The following is a description of a gene set: studied in species Homo sapiens Any cellular process that depends upon or alters the microtubule cytoskeleton, that part of the cytoskeleton comprising microtubules and their associated proteins. Human Gene Set: GOBP_MICROTUBULE_BASED_PROCESS, and this is the list of marker genes: IQCG, DNAI4, TUBB2A, SLC22A16, SKA1, CAPN6, CATSPER3, TAC3, KIF13B, KIFAP3, CWH43, CDK5, AP3M1, STMN3, NLRP5, NME7, CFAP45 (cilia and flagella associated protein 45), FOXJ1, TUBG1, CLXN, RNF19A, CFAP90, GARIN2, ARHGAP21, SUGT1, ENKD1, TUBA1A, NEURL1 (NCBI Gene Id 9148), ODF2, KXD1, SPIRE2, IRGC, DYNLRB1, SPAG16, VPS4B, KIZ, DYNC1I1, DRG1, NUMA1, BBS2, TCTE1, RTTN, TTLL7, CYLD, CETN3, HSPB1, CENPJ, MLH1, SEMG1, CHMP4B, MAPRE1, IFT122, PARD3, NUDC, CYB5D1, CCDC102B, C2CD6, CPLANE2, FIGNL2, CCDC88A, GJA1, CFAP70, CALML4, PCNT, TUBB1, SMCP, KATNIP, BCCIP, NUF2, RSPH6A, DNALI1, VCP, DNAI2, CDK5R1, CEP350, STAG2, LSM14A, ACTR2, ABL1, CCDC78, KIF2B, KIF21B, TRAK2, ARL2, TMEM108, MAP1A, TRAF3IP1, HTT, CFAP46, CATSPER2, DNAL1, EPPIN, DNHD1 (dynein heavy chain domain 1), KLC4, IFT22, DRC7 (dynein regulatory complex subunit 7), TEKT2, CFAP58, CENPA, SPAG8, IFT52 (intraflagellar transport 52), DNAAF8, CEP20, CFAP206, CAMSAP1, PAX6, CCDC103, RHOT2, TRPV4, LZTS2, TNP1, KIF28P (NCBI Gene Id 100130097), DNAH2, PTPA, TOGARAM1, CCNB2, NEDD1, MECP2, CCDC61, CEP152, RP1L1, AKAP4, DNAH12, PARD6B, RAC1, ARMC2, SIK3, PKHD1, GOLGA2, BMERB1, SASS6, CCDC13, CLASP1, TUBB4B, APC, GIT1, KLC2, YIF1B, TTK, CCSAP, EPHA3, CCDC68, SPIRE1, PLK4, LRRC23, IFT20, CHMP7, IFT70A, DNAH14, TUBE1, KIF6, MEMO1, UHRF1, CCDC39, TMEM67, DNAAF6, DVL1, IFT172, ADCY3, EFHC1, FSD1, MCPH1, RCC1, DCLK2, RAB27B, E2F4, ATXN7, CDK11B, SKA3, PPFIBP1, BLOC1S5, AP3M2, WDR62, TLE6, GTSE1 (NCBI Gene Id 51512), TBCEL, IFT25, RAB6A, KASH5, CCDC38, CHMP1A, KIF16B, CFAP141, TPGS1, PEX14, APOB, TLN1, MAP1B, HAUS8, KIF13A, PURA, SLC39A12, IFT140, TUBGCP2, INO80, CLUAP1, KAT2A, CC2D2A, KIF5B (NCBI Gene Id 3830), PDCL2, SPAG1, PRC1, TTLL4, CFAP210, CHD3, CCNB1, CFAP161, TTLL8, SMC3, CCDC15, KIAA0753, CFL1, OCLN, CCDC40, FBXW5, DUSP21, PHLDB1, KNSTRN, KPNB1, CDCA8, NINL, C10orf90, KANK1, BLOC1S6, TEKTL1, PRM3, PFN4, RUFY4, CCDC66, KATNB1, USP33, CEP70, KIF26A, BIRC5, MAP7D3, DYNLRB2, MYBL2, ASPM, ZMYND10, BNIP2, CATSPERE, KIAA1614, DNAAF5, ATXN3, SPATA7, DYNLT4, SPA17, VANGL1, TTLL13, AKAP3, ZMYND12, TUBGCP3, CFAP65, INTS13, NEFH, DYNC2H1, BORCS8, DLG2, IQCA1L, CFAP276, SRGAP2C, CDH5, DYRK1A, SIRT1, KLHL42, NME5, ODAD2, ARHGEF7, MAP3K11 (NCBI Gene Id 4296), MAP7D2, TUBD1, KIF9, HOOK1, NIN (ninein, NCBI Gene Id 57681), NDEL1, CROCC, HAUS5, HDAC6, PIERCE2, SLIRP, PLK1, SRGAP2, UCHL1, TACC2, DNAAF11, PPP2R1B, SOD1, LCA5, IFT56, ATG5, AFG2B, HSPA1A, HSPA1B, KIF22, PARD3B, CEP97, FBXO5, POC1B, ARMC12, GAS2L1, PACRG, RNASE10, DNAAF3, KIF2A, PCM1, PKD1, ATP1A4, CKAP5, SPAG6, PTEN, WASHC5, BCL2L10, MAPK8IP3, RABL2B, ITGB1BP2, MNS1, CDKN1B, DYNLT3, CEP120, CDC20, CHORDC1, TMEM201, BRSK1, SENP6, TTLL5, CILK1, OFD1, CCDC8, FGF13, PARP3, AURKA, KIF12, ARL8A, EFHC2, POC5, TMEM230, PDCD6IP, TUB, TEKT5, DNAH5, RAN, KLC1, CFAP91, SON, KTN1, CIMIP2A, BORCS6, DNAAF1, SEPTIN4, DNAH1, NUSAP1, TPPP, CHEK1, CALML6, CSAG1, SDCCAG8, CUL9, APC2, CATSPERZ, GAS8, EML2, ERBB2, FIGN (NCBI Gene Id 80249), COPG1, SAPCD2, ILK, RAB1A, SLAIN1, CHMP3, HNRNPU, RIPOR2, CNTROB, BLOC1S2, INTU (inturned planar cell polarity protein), CRYAB, KIFBP, KIF3B, TBCD, KIFC2, RASGRP1, BORA, RFX3, EZR, CDC20B, CHMP2B, GMNC, HOOK2, SMC1A, ODAD3, FLOT2, ESPL1, TUBG2, GADD45A, ROPN1, MET, CEP128, CHMP5, GBA2, CLASP2, NEK6, AP3D1, EFCAB9, IFT27, KIF14, CCNF, CDK11A, UBXN2B, CCDC65, LZTFL1, ATF5, GAS2L2, UVRAG, NSFL1C, GK2, NPHP3, FBXO24, DNAAF2 (NCBI Gene Id 55172), SPEM3, HAUS4, DNAI1, DYNC2LI1, SKA2, CKAP2, SLC22A14, CEP43, ACTR10, GEN1, PGK2, RANBP1, STK11, SEPTIN1, FEZ1, CAV3, CFAP57, TBC1D21, SUN2, RPS3, PLK2, DST, KIF4B, SPMIP11, PRDM14, MAP7, MARK1, MAPK15 (NCBI Gene Id 225689), NAT10, ARL8B, TUBAL3, CFAP69, CLIP4, TRIM36, KIF2C, TTC21A, BBS12, DYNLT1, GABARAP, DNAH7, SPEF1, IQUB, PEX13, NAV3, RHO, CIMAP1A, RHOT1, LLGL1, CNTN2, RSPH1 (radial spoke head component 1), LRRC61, WDR35, SUN1, EML3, HSBP1, TEKT4, MCIDAS, CCNL2, RSPH9, RAB11A, DNM2, CABS1, KATNBL1, CCDC120, CHMP4C, HAUS2, STMN4, TUBA1C, ZW10 (NCBI Gene Id 9183), ALMS1, CFAP73, CFAP52, OOEP, MAP7D1, FUZ, INPP5B, CEP85, SPRY2, POC1A, MGARP, NEFL, RANGRF, HEPACAM2, DNAH9, PARD6G, BICD1, IFT70B, PSRC1, CDC14B, SYNE2, IQCA1, CHEK2, INCENP, AGBL4, TERF2, TUBB3, FKBP4, CDK1, ADAM7, DCTN1, NEK10 (NIMA related kinase 10), CEP76, CEP295, MOS, TEX101, HIF1A, PRSS55, KIF5A, HAUS1, RAB21, SPAST, LDHC, WDR90, RANBP9, SPMIP9, COPG2, TRAK1, CSNK1D, RAB17, PHLDB2, ATRX, ADCY10, KIF1C, SFPQ, PRKAA1, CEP19, AXIN1, UXT, SPG11, KATNAL1, MID1IP1, DYNC1LI2, SLK, UBE2B, PLK5 (polo like kinase 5 (inactive)), ZNF207, HAUS3, CDR2L, BLOC1S3, TTLL9, KIF21A, GNAI1, TRDN, IQCF1, CFAP119, C2CD3, CHP1, CNTLN, CELSR2, PRICKLE1, CAMSAP3, ACTR3, MARK4, MTCL1, TUBA3E, CLTC, HAP1, PEX1, NPHP4, MAPRE3, STAU2, CFAP107, MAPT, TUBB, DNAAF4, WDR19, CCNL1, RABGEF1, ING2, IFT74, CEP192, DLG1, DNAI3, CIMIP2C, EFNA5, KATNA1, CHMP6, TOGARAM2, SSX2IP, CATSPER4, DYNLL2, TACR1, NUP62, CFAP54, ANKRD53, GCC2, TACR2, XPO1, PLA2G3, LMNA, STAG1, FES, SPICE1, RIBC2, STARD7, CFAP43, NME8, IFT43, AQP4, KIF18A, DPCD, DNAH8, VDAC3, NCKAP5L, IFT81, MAP10, KIFC3, TRIM46, TTLL3, KIAA0319L, DIAPH1, MAP2, CDK2AP2, BLOC1S1, CCDC187, LRRC46, LRGUK, TSSK6, DYNC2I2, DRC1, DCTN2, NDE1, TTL, TUBA3C, GAS2L3, ANKFN1, CEP44, IFT57, CENATAC, TEKT3, TUBA4A, VPS13A, PLK3, CLIP3, TUBGCP4, CUL7, SLC9B2, NEK7, BAG3 (NCBI Gene Id 9531), RHOA, DZIP1, BRSK2, STMN2, DEFB1, PKD2, CAMSAP2, GAPDHS, SPC25, SPMIP8, HOATZ, SPDL1, DCAF13, MEIG1 (meiosis/spermiogenesis associated 1), KIF3A, PRUNE1, TXNDC9, BBS1, KIF7, GSK3B (NCBI Gene Id 2932), STMND1, DDB1, CFAP53, SPEM1, TUBB4A, ULK4, TNKS, JHY, TPX2, GSK3A, TBCB, AP3B2, CFAP221, KIF11, MAFIP, MARK3 (NCBI Gene Id 4140), CENPE, KIF19, CLN3, LLGL2, CCDC159, CETN1, KATNAL2 (NCBI Gene Id 83473), KIF27, DNAAF10, TACC3 (transforming acidic coiled-coil containing protein 3), LIMK2, TTC29, CEP126, STARD9, MAK, CCDC146, DNAJB13 (NCBI Gene Id 374407), MDM1, PPP2R1A, ZBED3, RAE1, GARIN3, QRICH2, PPFIA1, ARHGEF2, TRIM58, LCA5L, NDC80, NPM1, CCP110, HOOK3, CCSER2, TSSK4, BICDL1, KIF15, VBP1, SGO1, SPECC1L, RSPH4A, RACGAP1, EFCAB11, CGN, CCNYL1, TMF1, DAW1, ARMCX3, KIF1A, FNTB, PIBF1, BICDL2, STAU1, KLC3, ROPN1B, SEMG2, DYNC1I2, UBB, NAV1, TPR, WDR47, DYNC2I1, CFAP20, TTC12, DNAL4, FGF10, CCDC88C, RBM14, DNAH10, APP, KIF20B, DIXDC1, XRCC3, MAP4, HAUS7, NTMT1, RP1, MKKS, CCR6, CDC14C, LAMP1, GAPDH, TUBA1B, HDAC3, CFAP100, ARL3, CEP63, EFHB, FBXW11, TTLL1, CRYAA, MAP2K1, NCOR1, PPP1R12A, DYNLL1, DCTN3, PGAM4, NETO1, CEP72, CHMP1B, XRCC2, TAOK1, WNT3A, AP3S2 (adaptor related protein complex 3 subunit sigma 2), DYNC1LI1, ASH1L, TUBB8B, WEE1, ROCK1 (NCBI Gene Id 6093), KIF23, ROCK2, AKAP9, WASF1, TTLL11, ROPN1L, SPMIP6, TTLL2, OBSL1, CFAP97D1, TTC21B, NHERF1, PRKAA2, FAM110A, IFT80, DOCK7, AURKB, SETD2, NUBP1, ABRAXAS2, TUBB6, STMN1, MAP6, SPACA9, GTF2B, CFAP157, DEUP1, TAC1, SSNA1, CFAP61, MISP, TAC4, KAT2B, DYNLT5, CENPH, BCAS2, TUBA3D, RUFY3, CEP295NL, CDC14A, PPP1R35, CALML5, ITGB1, FYCO1, CFAP77, WRAP73, CCDC63, LRPPRC, CIB1, BORCS7, RMDN1, CFAP126, TMEM232, EML4, KIFC1, TACC1, SBDS, SYBU, DNAH6, OPA1, CFAP144, TEKT1, SLC16A1, KAT5, ODAD1, ATAT1 (NCBI Gene Id 79969), AUNIP, CFAP95, SLAIN2, BRCA1, KIF18B, SPAG17, TRIM54, MAP1S, DNAH3, KIF25, FSIP2, MREG, SORD, KIF3C, FLNA, MAP9, TRIM37, CATSPERD, FER, CCDC170, PLTP, TACR3, SPAG5, DCX, ATP2B4, ABRAXAS1, STIL, DIAPH3, TUBB8, RPGR, AURKC, KIF5C, PAFAH1B1, IGBP1, RNF4, DISC1, CCDC42, BBS4, KIF17, CFAP298, CFAP68, AP3B1, SPMIP10, APBA1, GPSM1, CFAP251, DNAH17, SAC3D1, PCLAF, MACF1 (microtubule actin crosslinking factor 1), CFAP44, MYH9, CHMP4BP1, PIERCE1 (piercer of microtubule wall 1), TBCE, ENKUR, ZPR1, CDK2, POLDIP2, KIF4A, WDR73, ARHGEF10, IFT46, RANBP10, FAM107A, CHMP2A, CEP68, SS18, TTBK2, CCDC69, IFT88, ODAD4, MAD2L1, MID1, HAUS6, EML1, CLIP1, CEP135, TUBB2B, CCDC57, HYDIN, BBOF1, AGTPBP1, PRKCZ, PIN1, TPPP3, ATG16L1, DCTN6, INPP5J, RGS14, CEP250, PPP2CA, MAPRE2, KIF26B (NCBI Gene Id 55083), DLGAP5, CETN2, RAB6C, CABYR, SPRY1 (sprouty RTK signaling antagonist 1), TUBGCP5, PARD6A, KIF20A, SLC9B1, CHMP4A, CELF3 (CUGBP Elav-like family member 3), ARMC3, SAXO4, CFAP74 (cilia and flagella associated protein 74), TUBA4B (tubulin alpha 4b), TEKTIP1, TUBGCP6, DAG1, BRCA2, TPPP2, TUBA8, BLOC1S4, BORCS5, PPP2CB, CTNNB1, EFCAB6, HDGFL3, CLIP2, MZT1, DNAH11, PAK1, MAP6D1, SPG7, DYNLT2B, NEK2, SNCA, DDX4, DYNLT2, DYNC1H1, INPPL1, CCDC88B (coiled-coil domain containing 88B), AAAS, STK36, FIGNL1, KIF24, CRIPT, GPSM2, SPEF2, DTNBP1, CATSPER1, NCKAP5, SLC9C1, PDE4DIP, CEP131, CDK5RAP2, RIBC1, PPP2R3C, CEP78, FMN2, CDC42, AP3S1, WDPCP, CFAP47, MARK2, SNAPIN, TTLL6, BICD2, FNTA, KIF1B